Given this list of marker genes PFKFB2, AP1G1, TEAD1, KLHL9, DNAJB3, WNT8B (NCBI Gene Id 7479), ZZZ3, FN1, LEP, UVSSA, RAB5C, RNASEH2B, WASF3, EIF4G2, LPCAT3, CDH8, TRPC5OS, CYYR1, SERINC5, CLEC5A, SLC44A5, LRRTM2, BASP1, CD164, TBC1D23, PPARGC1A, COX8A, HIPK1, EPG5 (NCBI Gene Id 654033), CGN (NCBI Gene Id 57530), SHANK2, OCM2, TBL1XR1, ETV1, ONECUT2, FHL1, SNN, RAPH1, CDK19, LGI2, KCNH8, RBM47, JMJD6, RNF146, NR6A1, BPIFA1, MAN1A2, MYO1C, DNAJC19, ZNF37A, SV2B, IPO8, OCM, CSMD3, SPAG9 (NCBI Gene Id 9043), PVR (PVR cell adhesion molecule), EIF5B, CEP350, CAMK1D, FAM111B, ZCCHC14, DYRK1A, SLK (STE20 like kinase), PPP4R3A, ZBTB10, SCN8A, NDRG2, TSHZ2, ESRP1, SKIL, ARHGAP21, ARMCX3 (NCBI Gene Id 51566), NKAIN2, PPP3R1, PAQR9, CAP2, LDLRAD4, ARID2, GLTP, B3GAT2, ALDH1A2 (NCBI Gene Id 8854), FAM120A, PIPOX, MAPK9, IL31, PDS5A, APPL1 (adaptor protein, phosphotyrosine interacting with PH domain and leucine zipper 1), FAM78B, AHCYL1, MATR3, MED1, RB1, CDK9, NEDD9, LPP, STK16, DNALI1, STX6, RAP1B, LRRN1 (NCBI Gene Id 91907), RC3H1, TET2, ZNF148, MEF2C, NEB, COL12A1, PRKCE, COL1A2, EPS15, ZSWIM6, ASXL1, APP, SBF2, MAML1, NICN1, MYB, ZBTB8A, PRELP, ANAPC7, GRB10, PLEKHA8, PAK3, EDAR, TRIM71, CAMK2D, DZIP1, NTRK2, NDRG3, HYOU1, LRIT3, HS3ST4, NADK, H2AZ1, STAT3, ATP1B1, ANP32E, MAGI3, IQCH, ARK2N, PLEKHO2 (NCBI Gene Id 80301), ATP2C1, PKD2 (polycystin 2, transient receptor potential cation channel), KCNA1, CDC26, CAPN6, PTCHD1, SRRM4 (serine/arginine repetitive matrix 4), PDK3, RUBCNL, IP6K3, SPINK6, XPO4, GPC6, KHDC4, PTPN2, FCHO2, POGZ, ALOXE3, CLSTN2, GRID2, ZMYND11, ZC3H10, GDI1 (NCBI Gene Id 2664), RABEPK, RIMS3, CTNND1, SLC24A2, PSMC2, MAPK1, MYO5B, WIPI2 (NCBI Gene Id 51623), DNER, ING2, LMBR1, APBB2, OGG1 (8-oxoguanine DNA glycosylase), SH3PXD2A, PTGFRN, POLR1B, UBR1, GPR52, TBX19, IRF2, CCDC88A, DIPK2A, here is a description of the gene set: Human Gene Set: MIR298 species: Homo sapiens from publication Chen Y, Wang X (PMID 31504780) Genes predicted to be targets of miRBase v22 microRNA hsa-miR-298 in miRDB v6.0 with MirTarget v4 prediction scores > 80 (high confidence targets).